The following is a description of a gene set: studied in species Mus musculus Kinesins Mouse Gene Set: REACTOME_KINESINS, and this is the list of marker genes: Kif9, Kif21a, Tubb2b, Kif5a, Kif27, Kif2b, Kif2a (NCBI Gene Id 319353), Tubb4b, Tuba3b, Tuba1c, Kif23, Kif18a, Tuba8, Kif12, Tubb2a, Kif3c, Kif1c, Kif2c, Tubb1, Kif6, Kif20a, Tubb3, Kif1b, Kif26b, Kif3a, Racgap1, Kif13b, Kif15, Kif28, Tuba3a, Kifc2, Kif4, Tuba4a, Klc3, Kif5b, Tubal3, Tubb4a, Kifc1, Kifap3, Kif26a, Kif3b, Kif16b, Kif11, Klc2, Klc1 (NCBI Gene Id 16593), Kif18b, Kif19a, Kif22, Tuba1a, Tuba1b, Tubb6 (NCBI Gene Id 67951), Kif20b, Cenpe, Kifc5b, Kif21b, Kif1a, Klc4